The following is a description of a gene set: studied in species Mus musculus Mouse Gene Set: GOBP_REGULATION_OF_MRNA_METABOLIC_PROCESS Any process that modulates the frequency, rate or extent of mRNA metabolic process., and this is the list of marker genes: Rida, Celf6, Trim71, Dhx34, Rbm25, Ago2, Pkp1, Celf2, Dhx9, Tia1, Kat8, Upf3b, Nanos3, Fxr2, Piwil1 (piwi-like RNA-mediated gene silencing 1), Mbnl1, Adam3, Tra2a (transformer 2 alpha), Sltm, Rbmxl1, Hnrnpa2b1, Celf5, Mapkapk2, Rbpms2, Cnot3, Rbmy, Gdnf, Apex1, Caprin1, Srsf12, Tnf, Safb, Qki, Ikbke, Tnrc6c, Tent5d, Alkbh5, Zbtb7a, Thumpd2, Mov10, Zc3h14, Adarb1, Zfp36l3, Nsrp1, Zc3h12a, Khdrbs2, Myod1, Mir7578, Srpk1, Rbmyf6, Ddx5 (NCBI Gene Id 72118), Clns1a, Tut4, Rbmxl2, Tob1 (NCBI Gene Id 22057), Pum2, Apobec1, Ahcyl1, Sap18, Elavl4, Parn, Nanos2, Scgb1a1, Ptcd2, Hnrnpr, Nicol1, Cnot8, Ago1, Tnrc6a, Dcps, Dicer1, Eif1, Khsrp, Rbm47, Pan2, Wdr77, Tbrg4, Rbm33, Mettl14, Nanos1, Ptbp3, Mir451b, Lmntd2, Cdk9, Ythdf3, Ythdf2, Vip, Cnot1, Srsf7, Zar1, Traf5, Hnrnpc, Mbnl2, Pabpc1, Fxr1, Ncl, Hspa8, Fastkd2 (NCBI Gene Id 75619), Arb2a, Fastkd3, Btg2, Cpeb1 (NCBI Gene Id 12877), Dyrk1a, Tut7, Rbm46, Dnd1, Srpk2, Cacng7, Piwil4, Gigyf2, Myd88, Rbm15b, Boll, A1cf (APOBEC1 complementation factor), Rc3h2, Fastk, Pcid2, Vim, Patl2, Nova1, Patl1, Dcp2, Igf2bp2, Cnot7, Rbmx, Hmx2, Ythdc1 (YTH domain containing 1), Zc3hav1, Igf2bp3, Cpeb3, Thrap3 (NCBI Gene Id 320018), Mir196b, Pnldc1, Dhx36, Dcp1b, Mir451a, Mir196a-2, Magoh, Traf3ip2, Srrm1, Mettl16, Syncrip, Hnrnpd (heterogeneous nuclear ribonucleoprotein D), Snrnp70, Exosc10, Puf60, Rbmyf9, Cirbp, Srsf2, Tra2b, Hnrnpa0, Hnrnpk, Mettl3, Srsf3, Upf1, Zfp64, Sfswap, Rbm24, Snw1, Prr5l, Rbm7, Celf3, Mir196a-1, Zfp36l1, Pabpc4, Pan3, Ythdf1, Sap18b, Igf2bp1, Nup98 (nucleoporin 98), C1qbp, Mir144, Angel2, Rbm8a2, Srsf8, Mex3d, Larp7-ps, Eif4enif1, Prpf19, Polr2g, Pabpc2, Carhsp1, Rbm10, Ddx17, Fmr1, Rbm5, Rbfox2, Bag4, Rbm4, Zfp36, Pum1, Lsm1, Pde12, Ybx2, Rbfox1, Paip1, Senp1 (SUMO1/sentrin specific peptidase 1), Eif4a3l2, Acin1, Safb2, Prmt5, Rnasel, Fto, Tnrc6b, Tardbp, Hnrnpl, Cnot6l (NCBI Gene Id 338514), Mtor, U2af2, Eif4a3l1, Ago3, Tent5b, Fastkd5, Srsf1, Rbfox3, Elavl1, Gm7324, Larp4b, Zc3h12d, Sf1, Gtsf1, Traf2, Samd4, Ybx1, Csde1, Cnot2, Fip1l1, Ccnb1, Arid5a, Prdx6b, Hdac7, Smu1 (NCBI Gene Id 80521), Rock2, Dis3l2, Ttc5, Rbm20, Tirap, Pabpn1l, Noct, Samd4b, Tent5c, Brf1, Slc11a1, Rbm3, Rbm8a, Fastkd1, Khdrbs3, Arglu1, Celf1, Srrm4, Ncbp1, E2f1, Eif4a3, Son, Fus, Malat1, Tent4b, Srpk3 (serine/arginine-rich protein specific kinase 3), Rbmyf3, Dcp1a, Nbas, Casc3, Prdx6, Calcr, Celf4, Vegfa, Wtap, Csdc2, Pabpn1, Rbm38, Srsf4, Pcbp4, Pkp3, Rbm42, Mir466l, Slirp, Plekhn1, Jmjd6, Secisbp2, Npm1, Slc39a5, Upf3a, Rest, Il17a, Piwil2, Iws1, Rbpms, Larp7, Mlh1, Dazl, Larp1, Srsf9, Nova2, Nrde2, Gtpbp1, Cnot6, Rc3h1, Rbm15, Khdrbs1, Rbm11, Rbm39 (RNA binding motif protein 39), Ptbp1, Supt6, Hnf4aos, Dazap1, Fam76b, Tent4a, Meioc, Taf15, Obi1, Hnrnpu, Rbmyf1, Cdc73, Srsf10, Srsf6, Rock1, Hnrnpab, Magohb, Tent5a, Zfp36l2, Axin2, Rnps1, Pnpt1, Akr1c6, Pias4